The following is a description of a gene set: Signaling by TGFB family members studied in species Homo sapiens Human Gene Set: REACTOME_SIGNALING_BY_TGFB_FAMILY_MEMBERS, and this is the list of marker genes: CER1, FOXH1, STAT1, PPP1R15A, INHBA, FST, FKBP1A, LTBP4, CCNT2, RNF111, UCHL5, BMPR1A (NCBI Gene Id 8035), TIMP1, UBB, NCSTN, MYC, MIR23B, APH1A, TFDP1, RBL1, E2F5, SMURF2, NEDD4L, AMH (NCBI Gene Id 268), SNW1, PARD3, AMHR2, TGIF1, MIRLET7A1, SMAD3, COL1A2, NOG, TCF3, DRAP1, STUB1, PMEPA1, TRIM33, MEN1, BMP2, ATP1B4, PPP1CA, KLF16, USP15, HELLS, XPO1, LTBP3, TGFB3, BMP10, MIR27B, WWTR1, USP9X, CDK8, BMPR2, MTMR4, SMURF1, TGFBR1, TGIF2 (NCBI Gene Id 60436), SMAD4, SMAD1, NCOR1, INHA, MMP16, UBA52, TFDP2, CGN, MAPK3, MYF5, MYOD1, ARHGEF18, GDF2, ACVR1C, ARRB1, GIPC1, TGFBR2, TNRC6B, GREM2, ACVR1B, FSTL1, FGF2, CDKN2B, ITGB8, SMAD7, ZFYVE16, MYOG (myogenin), PSENEN, CCNT1, TCF12, UBC, AGO4, RXRA, TNRC6A, TGFBR3, MMP14, BAMBI, AGO3, SMAD6, MOV10, TNRC6C, E2F4, FSTL3, PRKCZ, MAPK1, RPS27A (NCBI Gene Id 6233), EP300, SMAD5, SMAD9, CHRDL1, NEDD8, LTBP1, AGO1, ITGB5, STRAP, ITGB3, FBN1, SERPINE1, SKIL, ARRB2, TIMP2, RHOA (NCBI Gene Id 387), UBE2M (NCBI Gene Id 9040), TGFB1, CDK9, PARP1, JUNB, UBE2D1, PSEN2, PARD6A, MYCN, HDAC1, ITGA8, ACVR2A, TCF4, SP1, ITGB6, CCNK, LTBP2, AGO2, TGFB2, YBX1, CCNC, APH1B, F11R, RARA, ITGB1, MYF6, NCOR2, CBL (Cbl proto-oncogene), ACVRL1, PPM1A, SMAD2, ZFYVE9, INHBB, PSEN1, FURIN, PPP1CC, UBE2D3 (ubiquitin conjugating enzyme E2 D3), PPP1CB, SKI, BMPR1B, ITGAV, ACVR2B